Given this list of marker genes AIM2, CAPN9, USP21, ATXN3, LTF, UFSP1, BAP1, CTSO, USP6, CST6, USP1, CSTL1, FETUB, USP4, BLMH, OTUD7B, USP42, HRG, USP24, PYCARD, USP3, SPOCK1, CST9 (NCBI Gene Id 128822), ZUP1, SCRN1, USP17L24, CTSC, CASP14, PGPEP1L, USP17L11, USP17L4, USP17L2, ALG13, USP43, USP45, USP29, ATG4A, CAPN10 (NCBI Gene Id 4812), USP28, ADGB (androglobin), SENP2, USP17L5, CASP6, SCRN2, CAPN14, SFRP1, SENP5, NLRP3, USP32, RCE1, CST8 (cystatin 8), CSTA, USP11, USP48, TIMM50, CST9LP1, CASP7, USP17L15, USP46, JOSD2, USP17L13, LGMN, USPL1, CAST, CASP3, TINAG, CST11, SERPINB13, CST4, MALT1, CAPN1, VCPIP1, USP17L19, ATG4B, CST2, CTSK, NLRP1, OTUD6B, USP19, USP25, UFSP2, CTSL, USP8, USP51, CTSB, USP17L10, TRHDE, BIRC7, USP17L18, USP26, CFLAR, USP31 (ubiquitin specific peptidase 31), USP2, CST7, CASP9, OTUB2, AHSG, TANK, CASP4, SENP1 (NCBI Gene Id 29843), CAPNS1, CAPN6, USP13, ESPL1, CAPN8, SENP7, EIF3F, CST3, WFDC2, CASP12, CASP10, USP9Y, HINT1, ZRANB1, GPAA1, KNG1, SCRN3, UCHL3, MINDY4, LCN1, CASP5, CYLD, USP49, USP35 (NCBI Gene Id 57558), MINDY1, BAD, OTUD3, USP17L8, CARD17P, UFD1, OTUD1 (OTU deubiquitinase 1), USP22, USP17L1, USP17L6P (NCBI Gene Id 391628), SNCA, CTSZ, USP39, USP14, USP36, XIAP, ZC3H12A, CASP2, USP17L3, CARD18, CTSH, SENP6, OTUD4, CAPNS2, MINDY4B, CTSS, USP16, NLRP12, USP17L12, CAPN12, CST1, SENP8, GGH, HSPD1, CST5, USP7, CTSD, CAPN15, MINDY2, NAIP, UCHL5, USP44, USP17L21, SERPINB3, ATXN3L, SENP3, USP5, USP34, CAPN5, PIGK, CTSW, CSN2, UCHL1 (NCBI Gene Id 7345), OTUD7A, CST9L, USP15, CASP1, USP20, USP30, ST20, JOSD1, PGPEP1, CASP8, USP33, PDIA3, CAPN11 (NCBI Gene Id 11131), USP10, USP27X, YOD1, USP47, USP17L20, DESI2 (NCBI Gene Id 51029), OTUD6A, USP54, CAPN13, USP38, USP17L22 (NCBI Gene Id 100287513), CSTB, ATG4D, PAN2, APAF1, MINDY3, BIRC6, USP9X, USP53 (ubiquitin specific peptidase 53), USP18, CAPN7, OTULIN, TNFAIP3, USP37, DESI1, BIRC5, USP17L17, PTTG1, CARD16, CTSV, CAPN2, CAPN3, CARD8, OTUB1, OTUD5, USP17L7, TINAGL1, BRCC3, ATG4C, USP12, USP17L23, CTSF, ACTMAP, USP40, USP50, PIGU, here is a description of the gene set: studied in species Homo sapiens Human Gene Set: GOMF_CYSTEINE_TYPE_PEPTIDASE_ACTIVITY Catalysis of the hydrolysis of peptide bonds in a polypeptide chain by a mechanism in which the sulfhydryl group of a cysteine residue at the active center acts as a nucleophile.